Given this list of marker genes Srgap2, Sri, Ubr5, Stc2, Phax, Atxn1l, Fn1, 4930563E22Rik (RIKEN cDNA 4930563E22 gene), Arcn1, Bsn, Fam168a, Wnk3, Zfp36l2, Thbs1, Actb, Nol4l (nucleolar protein 4-like), Utrn, Vamp2, Zfp800, Tnks2, 1700066M21Rik, Hmbox1, Tmem243, Ttc7b, Gnpda2, Atg13, Lrch1, Slc29a3, Dennd6a, Hmcn1, Hycc1, Nfatc2, Klf4, Ss18, Tex2 (testis expressed gene 2), Ddx5, Atp6v1a, Cav2, Slc25a53, Dnajc6, Pirt, Slc25a25, Phf6, Zfp661 (zinc finger protein 661), Trappc4, Ajuba, Nfatc3 (NCBI Gene Id 97460), Srsf9, Igf1, Tbp, Cdc14a, Meox2, Cfap47, Atf2, Tpm3, Ust, Gclc, Kif2a, Nexmif, Cped1, Ccdc166, Plppr4, Mmd, Prkce, Tars2, Thoc2, Lasp1, Rnf145, Tmem178, Ppib, Entpd7 (ectonucleoside triphosphate diphosphohydrolase 7), Dach1, Smarcc1, Mctp1, Phyhip, Slc38a3, Clcn3, Map1a, Tspan4, Elf1, Rabgap1l, Wnt3, Arf3, Frmd3, Col25a1, Bcl11a, Cndp1, Zfp280d, Mtx1 (metaxin 1), Serp1, Myocd, Stk39, Ap1s1, Mfsd14a, Wdr48, Thrb, Man2b1, Clock, Ywhab, Marchf1 (NCBI Gene Id 72925), Twf1, Tpm4, Dph6, Ube4a, Rrm1, Adgra3, Scaf11, Spred1, Sprn, Anxa2, Rbm27, Frs2, Folr1, Glce, Stard7, Syn3, Xpo6, Kalrn, Azin1, Hoxb4, Arap2, Rgs19, Nedd9, Ywhaz, Pgrmc1, Mpp7, Nlrp4e, Eml3, Slc39a10, Coro1c, Bach2, Neto1, Mex3c, Sash1, Usp33, Ddx17, Eeig1, Spire1, Alkal2, Cebpz, Nxt2, Rnf138, Jade3, Hacd3, Mapkbp1, Ms4a7, Plxna4, Prlr, Tgfbr3, Gja1, Snx2 (NCBI Gene Id 67804), Ip6k2, Nup50, Cdk6, Helz2, Trim2, Sp2, Ets1, Matr3, Pdik1l, Pip4p1, Mal2, Crem, E2f5, Cdk14, Adpgk, Arfip1, Tmcc1, Ppp4r2, Glcci1, Josd1, Wbp1l, Cap1, Rictor, Hnrnpu, Rit2, Cd2ap, Suz12, Fbxo33, Nxph2, Uts2r (NCBI Gene Id 217369), Msantd2, Lrrc8a, Adar (adenosine deaminase, RNA-specific), Cttnbp2nl, Tnpo2, Pax7, Fnip2, Rnf150, Hinfp, D6Wsu163e, Caap1, Tra2b, Glis2, Obsl1, Tmsb4x, Ube2h, Kank4, Cbl, Eif1ax, Tppp, Nrp1, Mylk, Knop1, Creb5, Eva1a, 9230112D13Rik, Sec61a1, Stag2, Kmt2e (lysine (K)-specific methyltransferase 2E, NCBI Gene Id 78559), Ank3, Kcnd3, Sema6d, Kcnip3, Slc25a22, Pla2g4a, Cited2, Rfesd, Ndrg1, Hmgn1, Ark2c, Ccr1l1, Timp3, Chsy1, Arhgap25, Bdnf, Ncoa1, Dach2, Max, Adprm, Ankrd29, Pdcd10, Cmpk2, Kctd10, Gpr158, Sec22b, Bltp3b, Cnn3, Pde7a, Edn1 (endothelin 1), Fndc3a (NCBI Gene Id 76636), Mmd2, Ptprg, Kat6a, Pik3c2a, Smim14 (small integral membrane protein 14), Snai2, Stmn2, Foxp1, Dgke, Ktn1, Hs3st3b1, Tbc1d15, Map4k3, Tex11, Serpinf1, Tmem18, Hipk3, Larp4, Asxl3, Arf4, Pax3, Cask, Sox17, Unc119b, Setbp1, Wars2, Git1, Zfp740, Trappc3, Sulf1, Tspyl4 (TSPY-like 4), Osbpl7, Peak1 (pseudopodium-enriched atypical kinase 1), Mecom, Smarcb1, Slc37a3, Ccsap, Syt1, Prkacb, Esp34 (exocrine gland secreted peptide 34), Zc3h7b, Zfp40, Phip, Hsp90b1, Raver2, Fndc3b, Ncl (NCBI Gene Id 319677), Grk6, Gpd2, Hspd1, G6pdx, Ndrg3, Yipf4, Dlg1, Mon2, Miga2 (NCBI Gene Id 99073), Sec63, here is a description of the gene set: Mouse Gene Set: MIR_6382 Genes predicted to be targets of miRBase v22 microRNA mmu_miR_6382 in miRDB v6.0 with MirTarget v4 prediction scores > 80 (high confidence targets). studied in species Mus musculus from publication Chen Y, Wang X (PMID 31504780)